The following is a description of a gene set: Any process that results in a change in state or activity of a cell (in terms of movement, secretion, enzyme production, gene expression, etc.) as a result of a prostagladin E stimulus. studied in species Mus musculus Mouse Gene Set: GOBP_CELLULAR_RESPONSE_TO_PROSTAGLANDIN_E_STIMULUS, and this is the list of marker genes: Prkaa1, Sfrp1 (secreted frizzled-related protein 1), Acaca, Akap8, P2ry6, Ptger4, Tnfsf4, Akt1, Prkaa2, Ptger2, P2ry4, Gnas, Prkce, Adcy6, Pax6